Given this list of marker genes RNASE2, RNASE3, FGA (NCBI Gene Id 2243), DMBT1, FGB, SPON2, here is a description of the gene set: species: Homo sapiens Human Gene Set: GOBP_INDUCTION_OF_BACTERIAL_AGGLUTINATION Any process in which infecting bacteria are clumped together by a host organism.